The following is a description of a gene set: A process in which a protein is transported to or maintained in a location within an axon. Mouse Gene Set: GOBP_PROTEIN_LOCALIZATION_TO_AXON species: Mus musculus, and this is the list of marker genes: Cntnap1 (contactin associated protein-like 1), Copa, Cntnap2, Cntn2, Trim46, Nfasc, Cope, Ank3, Mal, Epb41l3, Ugt8a